The following is a description of a gene set: Any process that stops, prevents or reduces the frequency, rate or extent of ERAD pathway. species: Mus musculus Mouse Gene Set: GOBP_NEGATIVE_REGULATION_OF_ERAD_PATHWAY, and this is the list of marker genes: Svip, Ubxn1, Usp25, Aqp11 (NCBI Gene Id 66333), Sgta, Ubxn2a, Usp14